Given this list of marker genes ZNF229, THBS1, ANKRD44, LNPEP, SDCBP, ABI3, CD79A, MAP4K2, CCRL2, AGER, ATP13A2, GRINA, ICOSLG, HELZ2, ACAP1, AKT3, RNASE6, SPATA6, IL9R, HLA-DOB, ARID3B, WDR1 (NCBI Gene Id 9948), RMND5B, UBA7, DOCK2, PITPNM1, PHF13, SELPLG, SUSD1, LRRK2, SLCO2B1, RNF38, MXI1, PIANP, ARL4A, MTA3, CBL, LPP-AS2, SLC8B1, BNIP3L, GTPBP2, GUCD1 (guanylyl cyclase domain containing 1), TLR1, RPL39, IRF2BPL (NCBI Gene Id 64207), IL6R, CA2, CERK, MSRB3, PTPRE, PIK3CG, TSC22D3, SIRT2, EEF2, ITM2B, DENND2D, RASA3, AFMID, RHD, CYBB, HECA, CNN2, DCK, CCNG2, COLCA1, LBH, SSH2, PTPRC, INPP5F, ZNF608, WNT10A, DGKA, WNT11, TSPAN13, GSE1, ARFGAP3, MINDY2, PARP8, HCST, ZP2, HLX, PARP4, RIN3, KLRD1, TNFAIP8L2, AP3B1, FHDC1, STK17B (serine/threonine kinase 17b), RETREG1, SMIM14, IZUMO4, ZFP69, CNR2, BAZ2B, GCNT1, FOXO4, MSN, TSGA10, ARHGEF18, POLR3GL, PDE3B, ANKRD13A, CDC42EP3, ADIPOR1, MAFB, MIDEAS, SMPDL3A, RB1CC1, TK1, MRGPRE, GAB3, TRAF5, TMED8, P2RY14, ABCA1, H3-5, MAPK11, TYROBP, PHF1, KLRC1, MBD4, TCP11L2, RAB8A, CTSF, RHOQ, MS4A6A, B3GNT8, WDR90, DENND1C, YPEL3, CPT1A, PPOX, FBXO32, TPT1, CREBRF, SERINC5, RFLNB, JUND, SEMA4F, BCL3, GDI1, SPICE1, PLEKHG2, CEMIP2, KDM7A, ABCD1, ROCK1, POU6F1, REEP5, CD3G, FLI1, PECAM1, MYLIP, AVP, DGKD, BMP2K, TP53I11, AQP1, ZFP36L2, STK10, LAPTM5, ATOSA, ARHGDIB, GRAMD4, LEPROT, MYH9 (NCBI Gene Id 65212), ZFAND5, CTSE, HEXB, PGAP1, PDE2A, PLA2G7, ABCG2, HACL1, MFAP1, PPP1CB, IFT172, ZNF260, BICRA, EVX1 (NCBI Gene Id 2128), RASSF2, TGFBR2, HEBP1, PLCG1, SIDT1, GNB4, EPAS1, TUBB1, MAK, LPCAT2, HIVEP2, GFOD1, PCMTD2, ITGB3, TMEM123 (transmembrane protein 123), CD1D, CYFIP2, SELL, TMEM86A, HPSE, here is a description of the gene set: species: Homo sapiens Genes up-regulated in CD4 SMARTA T cells: naïve versus memory follicular helper (Tfh). from publication Hale JS, Youngblood B, Latner DR, Mohammed AU, Ye L, Akondy RS, Wu T, Iyer SS, Ahmed R (PMID 23583644) Human Gene Set: GSE43863_NAIVE_VS_MEMORY_TFH_CD4_TCELL_D150_LCMV_UP CD4 T follicular helper (Tfh) cells provide the required signals to B cells for germinal center reactions that are necessary for longlived antibody responses. However, it remains unclear whether there are CD4+ memory T cells committed to the Tfh lineage after antigen clearance. Using adoptive transfer of antigen-specific memory CD4+ subpopulations (based on CXCR5 and Ly6c expression)in the LCMV infection model, we found that there are distinct memory CD4+ T cell populations with commitment to the Tfh and Th1 lineages. Our conclusions are based on gene expression profiles, epigenetic studies and phenotypic and functional analysis. The gene expression profiles of virus-specific CD4 T cell subets at effector and memory stages is presented here.